Given this list of marker genes Dnaja1, Atm, Ddit3, Park7, Stox1 (storkhead box 1), Atg5, here is a description of the gene set: Any process that results in a change in state or activity of a cell (in terms of movement, secretion, enzyme production, gene expression, etc.) as a result of a nitrosative stress stimulus. Nitrosative stress is a state often resulting from exposure to high levels of nitric oxide (NO) or the highly reactive oxidant peroxynitrite, which is produced following interaction of NO with superoxide anions. studied in species Mus musculus Mouse Gene Set: GOBP_CELLULAR_RESPONSE_TO_NITROSATIVE_STRESS